Given this list of marker genes AURKC, ZNF268, TLK2, CCNE2, LTK, MYCNOS, HIPK1, ERBB4, FAM20A, PDGFB, BRAT1, SGK2, PRDX4, CCNK, PDPK1, MAPK6, JAK1, MAP2K3 (NCBI Gene Id 92079), ZFYVE28, ADCYAP1, ABL2, PRKDC, HRG, TNKS, ILF3, RARRES2, CD4 (NCBI Gene Id 920), FGF18, FES, NUAK2, PFKFB4, BANK1, MKNK1, PDGFRA, CDK5R2, PYCARD, VEGFB, FKBP8, TAB2, TP53RK, FGF19, GPRC5A, WNK4, LATS2, NSD1, RIPK1, WNT5A, PRKCZ, CCL2, CSNK1D, CHP1, PEAK1 (NCBI Gene Id 79834), NUAK1, BCL10, PPP4R1, CSF1R, FER, ZFP91, MST1R, PHIP, MAD2L2, DRD4, IFNL1, RBKS, SEMA4D, AAK1, DYRK1B, C8orf44-SGK3, MRNIP, CARD10, SPHK1, CNOT7, SIK1, CSK, DGKD, RAP2B (RAP2B, member of RAS oncogene family), HIPK2, IL6, PFKM, PIM2, SIRT2, KDR, TSSK1B, ROPN1, TESK2, MAP3K11, CDKN1C, LACRT, MAP3K10, S1PR2, PLK2, DGKZ, GALK2, IL18, ITGB1BP1, TRAF6, MEN1, DIRAS2, PSEN1, POMK, IL21, MYLK2, CNTF, ABI2, DCLK1, NEK2, MACROH2A1 (macroH2A.1 histone), AGAP2, CAMK2A, FAXDC2, CCNT2, ABI1, DDR1, PRKCI (NCBI Gene Id 5584), FGGY, CTF1, MARK1, PIH1D1, GLYCTK, ROPN1L, PRKAG1, NEK1, UBE2K, ARRB1, RASIP1, ATG14, MAST1, C9orf72, PRKG2, MARK3, CREB1, PTK2B, CASS4, IGF1R, TOM1L1 (NCBI Gene Id 10040), MAPK9, CD74, XYLB, EPHB4, CDC25C, MAPK8, CHEK1, LYN, SRPX2 (NCBI Gene Id 27286), PTEN, HSPB1, PRKD1, CEACAM1, PLK3, HEG1, IRAK3 (NCBI Gene Id 11213), NIBAN1, CAMK4, PRLR, CDKN2A, ARHGEF5, SRPK1, DGKE, ARAF, EPHB3, CSNK2B, MIF, TRIB3, PPM1E, CDKN1A, NEK10, CLK3, NPPA, ZNF16, NEK4 (NIMA related kinase 4), ERN2, FGFR2, IL34, PIK3R4, PICK1, MAP3K8, PRKAA1, NEK11, PKN3, TSG101, CDC25A, TRIB1, MAPKAPK5, WEE2, SIK2, TNFRSF18, DUSP7, MCM7, COPS2, CSNK1E, RAP2A, HMGA2, NRG1, SESN2, IRAK1, LIF, EZH2, APC, PPIA, STK17A, DMTN, RAC1, MARK4, MAP2K1, STK3, DNAJC3, EPHB2, FGF1, XRCC5, MYLK, SMG8, UHMK1, GNPTAB, IGF1, TYK2, CDC25B, WARS1, DIRAS1, DNAJA1, FGFR3, CLSPN, TNFRSF10B, VPS25, COQ8B, SRMS, BMX, PRKCH, STK24 (serine/threonine kinase 24), ERG, TRAF4, SYAP1, VEGFA, HERC5, MMD2, MKNK2, HLA-DRB1, TNNI3K, IRGM, IGFBP3, THBS1, CALCA, PTPN6, ZGPAT, LDB1, EMP2, STK26, CORO1C, PKN2, NOP53, PIM1, TAF7, RNASEL, PIK3R6, BMP4, ACVR1B, BRAF, KALRN, NEK3, SYK, EPM2A, GADD45A, PDGFRB, ARL2BP, PFN2, IL20, PIM3, XRCC6, TRIM6, NLK, RASSF2, TSSK4, RBL2, NAGK, ADCY8, FN1, CD80, OXSR1 (oxidative stress responsive kinase 1), CCNE1, PLXNB2, LDB2, PIK3CD, SRCIN1, GRK7, CEP43, MAST2, AKTIP, PRKD2, DGKB, SOCS4, ETAA1, MMD, LIMK1, INSM1, IP6K3, NTRK1, PRKN (NCBI Gene Id 8004), YWHAZ, PTPN2, MAP3K5, TBX1, CDK10, CHI3L1, EGFR, AGT, ROCK1, PFKFB2 (6-phosphofructo-2-kinase/fructose-2,6-biphosphatase 2), IRAK2, CDKL1, PRRT1, MAP3K1, SIRT1, PELI2, ALS2, FLT4, PRR5L, LIPE, CACTIN, ZNF622, DGKG, BRSK2, FBN1, STAT2, HK3, GMFG, DIRAS3, DUSP1, MAP3K21, DOK7, SHPK, SASH1, FASTK, CSPG4, ERCC6, PXK (NCBI Gene Id 54899), PPP1R15B, RARA, BIRC6, CDK12, CNKSR3, BARD1, CEMIP, AKT3, ATM, ABL1, SERTAD1, PTPRJ, FGF16, SPDYA, NTRK2, ROPN1B, NDUFS4, LCP2, PROM2, EIF2AK4, CCL11, FGFR1 (fibroblast growth factor receptor 1), ERBB2, CDK2, TLK1, RALB, DGKH, TRAF3IP1, FLT3, RTRAF, CACUL1, PSMD10 (proteasome 26S subunit, non-ATPase 10), CEP85, PTK6, LIMD1, RASGRP1, SYNPO2, SDCBP, APOE, PRDX3, TNF, CDC42BPB, MAP3K20, MST1, KSR1 (NCBI Gene Id 8844), TARDBP, SFN, MAPK8IP1, WNK2, ITGB2, AIDA, TNIK, HES1, TRIM27, RGS14, CAB39, INSR, PKDCC, GALK1, CDC42BPA, RPS6KB1, EREG, HK2, HDAC3, CHEK2, NEK6, TKFC, FZD7, NEDD9, FGR, MAPK3, DBNDD2, NPRL2, ANG, EPHA7, PCK1 (phosphoenolpyruvate carboxykinase 1), ADARB1, TSSK2, EFNA1, TENM1, PDCD4, STK39, KIT, PARD3, ACP4, ANKLE2, NLRC5, TRIB2, STK38L, CNOT9 (CCR4-NOT transcription complex subunit 9), SLIT2, MORC3, MINK1, ZC3H12A, TOP1, MARK2 (microtubule affinity regulating kinase 2), SGK1, CCNT1, THBS4, PTPN1, STK16, RAP2C, ODAM, KIF14, PKMYT1, CTBP1, CARD14, FCSK, PANK2, ACVR1C, PAQR3, NPM1, TARBP2, PRKAA2, DYRK1A, RUNX3, PRKD3, PIKFYVE (NCBI Gene Id 387568), RPS6KA4, FGF7, KCTD20 (potassium channel tetramerization domain containing 20), ULK3, PHKG2, DEFB114, MELK, SAMSN1, STK33, DYNLL1, TLR6, AKT1, DDRGK1, DAPK2, DMPK, PIBF1, INHA, PLK4, FGF2, HTATIP2, DDR2, GPER1, TBCK, MAPK1, CDC6, GNE, MOK (MOK protein kinase), TIGAR, COPS8, CAMKK2, STK17B, LILRA5, FGFR4, LIMCH1, SRC, CREBL2, SNRK, DIPK2A (divergent protein kinase domain 2A), EPHB1, NEK7, ABI3, RIOK2, BMP2, RBL1, ROS1, S100A12, GSK3B, IFNL4, ADM2, MAP3K12 (NCBI Gene Id 7786), NRP1, INPP5F, EIF2AK1, GSKIP, PFKFB1 (6-phosphofructo-2-kinase/fructose-2,6-biphosphatase 1), ROCK2, CILK1, GMFB (NCBI Gene Id 2764), TNFSF18, GNPTG, MYO3A, RAF1, YWHAG, MMP9, TSPYL2, IL31RA, NHERF1, MVP, TPD52L1, AURKA (aurora kinase A), LCK, TGFBR1, MAP2K2, MERTK, ANGPT1, CDK11B, FLOT1, TNFSF15 (NCBI Gene Id 9966), HGS, HIPK3, ERN1, RPS6KA5, NT5DC2, GRK5, BTK (NCBI Gene Id 695), CLIP3 (CAP-Gly domain containing linker protein 3), ATF2, FAM20C, FLT1, CSNK2A3, CSNK1G2, TSSK6, CDKN3, STRADA, EEF2K, KNDC1, VRK1, PRKCD, CHMP6, OSM, CSNK1A1, MYOD1, ADAM10, MAP4K4, TEC, PTPN22, KHK, AGK, PTK2, STK11, ENG, GPRC5B, PIK3CG (phosphatidylinositol-4,5-bisphosphate 3-kinase catalytic subunit gamma), WNK1, DSCAM, ZBED3, ADAM17, CENPE, CAMK1, RPS6KA1, PLK1 (NCBI Gene Id 5347), RB1, CDK16, TSSK3, FGF10, LRRK2, RAD17, UNC119, BRSK1, HCST, AREG, UVRAG, TNFRSF10A, CDC42BPG, BCR, CCNYL1, CCNG1, TGFB1, BCCIP, MAP3K9, MAP4K3, HASPIN, SNX6, KDM4D, CDK11A, TFAP4, PRKY, CDK5RAP3, APLN, STK10, CCDC88A, PKD1, THPO, CAMK2B, TNK2, DYRK2, NADK (NAD kinase), COQ8A, TRAF2, CDK5R1, LEP, DYNAP, IBTK, PRKCQ, MAP3K7, PRKACB, DYRK3, MOB1B, MUSK, ACVR2A, MAP3K13, PIN1, STOX1, DSTYK, PDGFA, LATS1, EPHA4, WDFY2, PAK2, LIMK2, TXK, STK36, PKN1, FBH1, GCK, SMO, ADIPOQ, ITLN1, RAP1A, SLK, MT3, CCNY, ERRFI1, SIK3, CTSG, INCA1, SMG1, RIPK2, CADM4, SGK3, NPTN, DGKQ, DGKI, SOCS5, SNX9, CDC37, MAP3K6, EGF, TAF1, STK38, HKDC1, CIMAP3, PDK3, DAPK3, MATK, PRKX, WNK3, JTB, MAK, STAT3, ULK1, PTPN13, PANK3, TPX2, GCKR, PPP3CB, CDK2AP1, GTF2H1, LMO4, RAPGEF2, MAPK10, ELANE, ALK, HK1, BLM, DHX34, AKT1S1, JAK3, TNK1, CAMK2D, NIM1K, ANGPT4, EFEMP1, MAP3K4, MAP3K3, FIRRM, PRKCE, DAPK1, RHOA, GLMN, PGK2, TLR3, ULK2, SRPK2, SFRP2, RIPK3, CDK17, RACK1, KLHL31, TTBK1 (NCBI Gene Id 84630), ZAP70, DGKA, PASK, TOLLIP, GAS6, MAP4K1, STRADB, MYDGF, IL12A, SFRP1, CIB1 (NCBI Gene Id 10519), MAML1 (mastermind like transcriptional coactivator 1), CLK2, TCIM, CDK5RAP1, PRKG1, SERPINB3, PRKCA, HNRNPU, CDKN1B, CD300A, XBP1, MAPK15, ADAR, BLK, RYK, ECT2, SNF8, TBK1, TRPM7, NLRP2B, ENPP2, PTPRC, EFNA5, INSRR (insulin receptor related receptor), JAK2, LAT, ARHGEF2, RSPO1, SPRY2, CDK9, EPHA3, PLAUR, PARP14, LMTK2, TERF2IP, ERC1, PIK3R5, IL15, STK25, IFNG, TAOK3, TTBK2, MIDN, GRB10, MEX3B, HCK, PRKACA, LTF, RALBP1, THY1, PARP9, STK4, PDCL3, CDK1, PFKFB3, PRKCB, INHBA, CRIPTO, PDCD10, IL11, EEF1A2, PILRB, IKBKB, DEPTOR, FYN, C3, MAPK4, EIF2AK2, PINK1, PKIA, MAP4K2, FBLN1, GRK1, VRK2, here is a description of the gene set: The process of introducing a phosphate group into a molecule, usually with the formation of a phosphoric ester, a phosphoric anhydride or a phosphoric amide. studied in species Homo sapiens Human Gene Set: GOBP_PHOSPHORYLATION